Given this list of marker genes Itgb6, Rfng, Kpna4, Nlrp4b, Igsf1, Chmp6, Mtss1, Kat2b, Ikzf2, Mansc1, Fgf11, Stk26, Cxcr5, Gm6712, Hpcal4, Top1, Taok1, Tmem45a2, Mettl9, Fchsd2, Dach2, Igdcc3, Slc26a3, Zfp386, Pcdh8, Rspry1, Pcdh7, Col3a1, Runx3, Nup35, Galntl6, Tln1, Gnrhr, Foxg1, Dcc, Nin (ninein), Phtf2, Psma3, Ptbp2, Clec16a, Eloa, Ctnnd2, Oprl1, here is a description of the gene set: species: Mus musculus from publication Chen Y, Wang X (PMID 31504780) Mouse Gene Set: MIR_7012_3P Genes predicted to be targets of miRBase v22 microRNA mmu_miR_7012_3p in miRDB v6.0 with MirTarget v4 prediction scores > 80 (high confidence targets).